The following is a description of a gene set: Human Gene Set: GOMF_HISTONE_ACETYLTRANSFERASE_ACTIVITY species: Homo sapiens Catalysis of the reaction: acetyl-CoA + histone = CoA + acetyl-histone., and this is the list of marker genes: KAT8, USP22, CDY1, KAT5, NAP1L2, ING4, ING3, BRD1, BRPF1, CLOCK, HAT1, NAA50, BRPF3, BRCA2, KAT2A, JADE2, TADA2A, GTF2B, BAZ1A, EP300, CREBBP, ARRB1 (arrestin beta 1), KAT6A, KAT7, KAT6B, NAA40, MEAF6, NCOA3, TAF1, PYGO2, ATF2, TAF1L, NAA60, TAF10, KAT14, TAF9, MCM3AP, CDY2A, NCOA1, CDY2B, SRCAP, JADE1, GTF3C4, PHF10, KAT2B, CDY1B